Given this list of marker genes Sult1a1 (NCBI Gene Id 20887), Tomt, Fah, Dbh, Slc6a3, Comt, Dio3, Moxd2, Moxd1, Maoa, Dio2, Pde1b, here is a description of the gene set: The chemical reactions and pathways resulting in the breakdown of a phenol, any compound containing one or more hydroxyl groups directly attached to an aromatic carbon ring. Mouse Gene Set: GOBP_PHENOL_CONTAINING_COMPOUND_CATABOLIC_PROCESS studied in species Mus musculus